The following is a description of a gene set: Human Gene Set: NIKOLSKY_OVERCONNECTED_IN_BREAST_CANCER A single cancer cell contains large numbers of genetic alterations that in combination create the malignant phenotype. However, whether amplified and mutated genes form functional and physical interaction networks that could explain the selection for cells with combined alterations is unknown. To investigate this issue, we characterized copy number alterations in 191 breast tumors using dense single nucleotide polymorphism arrays and identified genes with copy number gain organized into 30 amplicons. Amplicons were distributed unequally throughout the genome. Each amplicon had distinct enrichment pattern in pathways, networks, and molecular functions, but genes within individual amplicons did not form coherent functional units. Genes in amplicons included all major tumorigenic pathways and were highly enriched in breast cancer-causative genes. In contrast, genes with somatic mutations in breast cancer were distributed randomly over the genome, did not represent a functionally cohesive gene set, and were relatively less enriched in breast cancer marker genes. Mutated and gained genes did not show statistically significant overlap but were highly synergistic in populating key tumorigenic pathways including transforming growth factor beta, WNT, fibroblast growth factor, and PIP3 signaling. In general, mutated genes were more frequently upstream of gained genes in transcription regulation signaling than vice versa, suggesting that mutated genes are mainly regulators, whereas gained genes are mostly regulated. ESR1 was the major transcription factor regulating amplified but not mutated genes. Our results support the hypothesis that multiple genetic events, including copy number gains and somatic mutations, are necessary for establishing the malignant cell phenotype. from publication Nikolsky Y, Sviridov E, Yao J, Dosymbekov D, Ustyansky V, Kaznacheev V, Dezso Z, Mulvey L, Macconaill LE, Winckler W, Serebryiskaya T, Nikolskaya T, Polyak K (PMID 19010930) Overconnected mutated transcription factors regulating genes within the breast cancer amplicome. species: Homo sapiens, and this is the list of marker genes: IRF8, HNF1A, POU4F2, TCF7L1, TP53, XBP1, SOX15, NFIX, HOXA4 (homeobox A4), MYOD1, POU2F1, CUX1, NFKB1, FOXP2, STAT1 (signal transducer and activator of transcription 1), NFYC, ATF2, MEF2C, ETV5, CRX, STAT4